The following is a description of a gene set: Genes down-regulated in comparison of naive vs effector CD8 T cells (3.5 days postinfection). Human Gene Set: GSE19825_NAIVE_VS_DAY3_EFF_CD8_TCELL_DN from publication Kalia V, Sarkar S, Subramaniam S, Haining WN, Smith KA, Ahmed R (PMID 20096608) species: Homo sapiens CD25, the high affinity interleukin-2 (IL-2) receptor alpha-chain, is rapidly upregulated by antigen-specific CD8+ T cells after T cell receptor stimulation. We demonstrated that during an acute viral infection, CD25 expression was dynamic, and a subset of virus-specific CD8+ T cells sustained CD25 expression longer than the rest. Examination of the in vivo fate of effector CD8+ T cells exhibiting differential responsiveness to IL-2 revealed that CD25lo cells, which were relatively less sensitive to IL-2, preferentially upregulated CD127 and CD62L and gave rise to the functional long-lived memory pool. In contrast, CD25hi cells that accumulate enhanced IL-2 signals, proliferated more rapidly, were prone to apoptosis, exhibited a more pronounced effector phenotype, and appeared to be terminally differentiated. Sustained IL-2 receptor signaling resulted in increased CD8+ T cell proliferation, higher granzyme B expression and exaggerated contraction after antigen clearance. These data support the hypothesis that prolonged IL-2 signals during priming promote terminal effector differentiation of CD8+ T cells., and this is the list of marker genes: MYG1, MRPS26, MRPL27, C1orf122, DUS3L, PIP4K2B, UQCC2, SYTL3, LAMTOR5, GTF2H4, HDLBP, GZMA, UBE2J2, MDFIC, SAP18, PSMC1, STUB1, DHCR7, FTSJ1, ANXA7, GLT8D1, PHYKPL, IL1RL2, BRF2, AAAS, ING3, NANS, PRADC1, CKS1B, GNG2, PRKRIP1, SREBF2, PIDD1, BID, IFI30, SCAP, COPS6, SAFB2, CHCHD1, PDCL3, XPNPEP1, UBE2E1, SERPINB6, DROSHA, NEK8, ZFP91, RIPK3, LRRK1, ACTN4, EXO5, MRPL36, RAF1, COX17, NDUFA8, CTSB, CDT1, FAM89A, RETREG2, PPP1R8, MED30, ZNF410, HTT, NDUFS4 (NADH:ubiquinone oxidoreductase subunit S4), THAP11 (THAP domain containing 11), DCPS, MYO1G, ORMDL2, PLXNC1, TFIP11, WRAP53, SMARCB1, ERH, GTF2H5, WDR6 (WD repeat domain 6), TUBB2A, ANAPC10, LGALS1, PTPRA, VWA8, MAPK3, PRDX2, CD48, STMN1, GIT1, PLEKHA2, SLC30A7, RTCA, COG6, SNRNP25, ZNF282, GARS1, ZNF32, TARBP2, PSMG3, ATRAID, MSL3, KIF18B, SLC38A10, NDUFAF3, PGP, GRPEL2, CDCA5, ARPP19 (cAMP regulated phosphoprotein 19), CEBPZOS, TBPL1, PYCARD, ATG4D, CSNK2A2, EIF2B4, HMGN5, CLSPN, SYVN1 (synoviolin 1), VTI1A, CMTM7, MRPL21, GTF3C6, DUSP19, IPO13, PGM2, RPAP3, TBC1D13, GHITM, ADPRH, AGPAT2, ZNF330, COX14, RUSF1, ANXA6, C6orf120, MRPL16, RACGAP1, PHLPP1, PSMC3, ADPRM, SELENOH, MCM9, UQCRQ, NBAS, LRRC8D, SMIM30 (NCBI Gene Id 402587), VTI1B, NUDT16L1, S100A6, BCKDK, DYNLL2, IFITM3, TICRR, TMEM222, MCM6, MRPS12, PLEC, CIT, BLVRA, UHRF1, FHOD1 (NCBI Gene Id 29109), UNC119, BCL2L12, PSMA2, RABIF, SLC37A4, POLD2, CUTA, MICAL1, GABARAPL1, NSDHL, AP1S1, NELFCD, NDC80, RPA2, ACP1, KANSL3, SCAMP3, NUDT21, AKIP1 (A-kinase interacting protein 1), FXN, SURF1, INTS3, DERA, CASP3, CDC20, ZNF672 (NCBI Gene Id 79894), RCE1, CENPM, CHMP6, BUD23, NDUFA11, HIP1, DDA1, PTDSS2, TUSC3, TLCD2, EIF4EBP2, TPGS2, DEGS1, ANXA2, VIM, FASN, SLC39A4, STK16